Given this list of marker genes Pds5a, Lig3, Dynll1, Terf1, Inppl1, Cdt1, Gtpbp4 (GTP binding protein 4), Hcrt, Trp53, Timeless, Atr, Mapk15 (mitogen-activated protein kinase 15), Gmnn, Enpp7 (ectonucleotide pyrophosphatase/phosphodiesterase 7), Atg7, Rad17, Ttf1, Wapl, Tipin, Fbxo5, Tspyl2, here is a description of the gene set: Mouse Gene Set: GOBP_NEGATIVE_REGULATION_OF_DNA_REPLICATION studied in species Mus musculus Any process that stops, prevents, or reduces the frequency, rate or extent of DNA replication.